The following is a description of a gene set: Human Gene Set: GOBP_REGULATION_OF_NEURON_PROJECTION_REGENERATION Any process that modulates the rate, frequency or extent of neuron projection regeneration, the regrowth of neuronal processes such as axons or dendrites following their loss or damage. studied in species Homo sapiens, and this is the list of marker genes: INPP5F, MIR221, PTN, MIR222, RTCA, MIR431, RTN4R, CERS2, BRAF, RGMA, KLF4, FIGNL2, ADAM17, THY1, MAP2K1, GRN, KREMEN1 (NCBI Gene Id 83999), SCARF1, NEO1, RTN4RL1, PTPRF, TNR (tenascin R), NTRK3, PTPRS, STK24, PUM2 (pumilio RNA binding family member 2), PRRX1, LRIG2, MAP2K2, KIAA0319 (NCBI Gene Id 9856), CNTF, SPP1, EPHA4